The following is a description of a gene set: Human Gene Set: WP_SEROTONIN_TRANSPORTER_ACTIVITY studied in species Homo sapiens Serotonin transporter activity, and this is the list of marker genes: IL1R1, ITGB3, STX1A, SLC6A4, NOS1, MAOA, PPP2CB, IL1B, TGFB1I1 (NCBI Gene Id 94988), TPH2, SCAMP2